Given this list of marker genes PLCB1, PRKCG, PLCB2, PLCB3, PLCB4, TACR3, TAC3, GNAQ, PRKCA, PRKCB, here is a description of the gene set: Human Gene Set: KEGG_MEDICUS_REFERENCE_TAC3_TACR3_PLC_PKC_SIGNALING_PATHWAY Pathway Definition from KEGG: TAC3 -> TACR3 -> GNAQ -> PLCB -> (Ca2+,DAG) -> PKC studied in species Homo sapiens TAC3-TACR3-PLC-PKC signaling pathway. Pathway ID: N00882. Pathway type: Reference. Pathway class: nt06323 KISS1-GnRH-LH/FSH-E2 signaling.